Given this list of marker genes ICOS, RPL26, BCOR, RARA, SLC37A4, RFXAP, STAT3 (NCBI Gene Id 6774), SAMD9, TCN2, GATA2, FANCC, ASXL1, GTF2H5, RPL11 (ribosomal protein L11), TLR3, FASLG, ZBTB16, TPP2, SASH3, CSF3R, CLPB, LRRC8A, TINF2, RPL5, ITCH, LRBA, STK4, FIBP, FDX2, ADA2 (adenosine deaminase 2), NABP1, CBL, VPS33A, TFRC, TRAF3, CAMK2B, MMAA, RPL35, TET2, FANCI, GTF2E2, CARS1, AP3D1, SPI1, RPL15, MSN, XIAP, MPLKIP, MMUT, ATRX, CRELD1, RPS29, PACS2, AARS1, SRP54, DOCK11, EIF2AK3, TCF3, WDR1, CIITA, EPG5, STAT4, IL7R, IKBKG, RMRP, WIPF1 (NCBI Gene Id 7456), RPS24, PIK3R1 (NCBI Gene Id 5295), G6PC3, TERT, RAC2, PIK3CG, FIP1L1, PTPN6, FANCE, LBR, AGA, ETV6, OTULIN, RNF113A, CASP10 (caspase 10), MTR, CDC40, KIT, CD79A, SF3B1, PPIL1, FANCG, SCO2, RPL8, PCCA (propionyl-CoA carboxylase subunit alpha), SRP19, GALE, STAT5B (NCBI Gene Id 6777), MMACHC, MMAB, CXCR2 (NCBI Gene Id 3579), FAS, SLC35C1, GSS, RUNX1, FANCA, MVK, ICOSLG, HSCB, CUBN, IFNG, RPL9, UNC13D, PML, C1GALT1C1, SEC61A1, RPS28, LAMTOR2, TCIRG1, RPS7, ERCC2, TLR8, NPM1, IL1RN, RPS19, IL36RN, SLC39A7, SLC46A1, VPS13B, PRKAR1A, AP3B1, JAGN1, RPL31, TARS1, SH2D1A, IRAK4, STXBP2, TSR2, FOXP3, SMARCD2 (SWI/SNF related, matrix associated, actin dependent regulator of chromatin, subfamily d, member 2), RAB27A, MDM4, FBXW7 (NCBI Gene Id 55294), RPS15A, RPS20, PRDX1, SRP68, NUMA1, PCCB, TDP2, TFR2, CXCR4, RELB, FMO3, UBE2A, TAFAZZIN, IRF8, MECOM, GINS1, MEFV, STX11, ZNFX1, PGM3, CD40, ERCC3, TONSL, RPS26, IGHM, TBL1XR1, RPS27, THPO, HAX1, SMARCAL1, SRSF2, FCGR3B, TERC, CEBPE, MTRR, ACP5, HEATR3, RECQL4, BTK (Bruton tyrosine kinase), MYSM1, KRAS, GATA1, RFXANK, ELANE, COG4, IL6ST, NRAS, RPL35A, RPS10, DIAPH1, TICAM1, DNAJC21, LYST, SBDS, ARPC5, STAT1, UNC93B1, ABCD4, RPL27, MAD2L2, IGLL1, SLC35A1, CD79B, VPS45, RFX5, RPS17, FUT8, IRF2BP2, CTLA4, RPL18, ANAPC1, NDUFA6, PRF1, LMBRD1, PIK3CD, HTRA2, FANCD2, AMN, TRAC, SLC30A7, FNIP1, PNP, FBXL4, USB1, TBK1, GFI1, RAG1, EFL1, CD40LG, SAMD9L, NCAPG2, WAS, BLNK, here is a description of the gene set: species: Homo sapiens Human Gene Set: HP_ABNORMAL_TOTAL_NEUTROPHIL_COUNT Abnormal total neutrophil count A deviation from the normal range of neutrophil cell counts in the circulation.